Given this list of marker genes Gstp1, Rasgrp1, Vsig4, Aif1, Golph3, Mia3, Hsp90aa1, Cd209e, Il36b, Fadd, Igfbp2, Lef1, Tsc2, Skap1 (src family associated phosphoprotein 1), Cblb, Xcl1, Arg2, Hes1, Arg1, Tnfrsf14, Zbtb7b, Il15, Ptprc, Skint1, Hsph1, Nkap, Smarcc1, Selp, Il4i1, Foxo3, Ywhag, Il6, Smarcd3, Tnfsf14, Ccl21d, Glmn, Slc39a8, Gm5849, Laptm5, Ptpn22, Btla, Il2rg, Arid2, Fgl2, Pdcd1, Erbb2, Vnn1, Mir326, Capn1, Vtcn1, Smarca4, Cyrib, Tnfsf4, Socs1, Cd209d, Zc3h12d, Il21, Ezr, Rc3h1, Klhl22, Lgals3, Zap70, Lilrb4a, Shb, Peli1, Cd81, Pnp, Ptpn2, Phf10, Tnfrsf21, Hspb1, Cd28, Itgb7, Egr3, Foxp3, Msn, Slc4a1, Cd177, Madcam1, Socs5, Sash3, Sart1 (NCBI Gene Id 20227), Mad1l1, Adora2a, Ap3d1, Adam8, Ap3b1, Cxcl12, Cd80, Tespa1, Ascl2, Itgam, Nt5e, Ripk2, Icosl, S100a8, Cd209c, S100a9, Rag1, Tnip1, Cd1d2, Rock1, Cyld, Spn, Dusp3, Vcam1, Chst2, Ambra1, Ccl21f, Il1b, Casp3, Malt1, St3gal4, Il1rl2, Anxa1, Gata3, Epo, Tgfbr2, Itpkb, Stat5b, Pdcd1lg2, Actl6a, Prnp, Kat5, H2-Ab1, Prkcz, Pycard, Jak2, Scgb1a1, Ccl25, Cd6, Ptafr, Runx1, Cd274, Sox13, Il2ra, Il4, Ccl28, Cd244a, Dlg1, Cav1, Smad7, Il12rb1, Ager, Rela, Il20rb, Brd7, Foxj1, Gnrh1, Tnfaip8l2, Ccr2, Fbxo38, Slfn1, Ephb4, H2-Eb2 (NCBI Gene Id 631971), Vsir, Il1a, Ada, Rag2, Actl6b, Flot2, Actb, Cbfb, Nlrp3, Tnfsf13b, Apoa4, Bmp4, Slc7a1, Itga5, Twsg1, Cd27, Ccl21e, Ccl21a, Opa1, Jam2, Bad, Ufl1, Itgb1, Ppara, Has2, Fut4, Ep300, H2-Ea, Sele, Cd47, Marchf7, Smarcb1, Lgals1, Cd24a, Fgl1 (fibrinogen-like protein 1), Nrarp, Irak1, Irgm1, Chst4, Hlx, Cd3e, Sftpd, Pecam1, Icos, Nfkbid, Bmi1, Lgals8, Tarm1, Sell, Akt1, Prkcq, Smarcd2, Igf1, Efnb3, H2-DMb1, Nfat5, Smarcc2, Gimap5, Bcl6, Nr5a2, Sox12, Lck, Wnk1, Zc3h8, Rhoh, Btnl2, Add2, Sema4d, Gimap3, Ctsg, Il23a, Slamf1, H2-DMa, Ccdc88b, Coro1a, Rac2, Rps3, H2-DMb2, Lax1, Brd2, Ndfip1, Tnf, Cd69, Mdk, Ets1, Loxl3, Dock8, Itga4, Lgals9, Il18, Cd55, Zbtb1, Cd59b, Zdhhc21, Pck1, Nck1, Pik3r6 (phosphoinositide-3-kinase regulatory subunit 5), Tbx21, H2-Ob, Ext1, Tfrc, Prkar1a, Dtx1, Pag1, Tnfrsf13c, Tgfb1, Jak3 (Janus kinase 3), Dpp4, Lilrb4b, Klhl25, Pbrm1, Lypd11, B2m, Nckap1l, Sirpa, Dusp22, Igf2, Prdx2, Pten, Klf4, Btn2a2, Blm, Cx3cr1, Card11, Zc3h12a, Nck2, Hmgb1, Cd44, Hfe, Fut7, Cd59a, Ptpn6, Pawr, Fcho1, Podxl2, Pla2g2a (phospholipase A2, group IIA (platelets, synovial fluid)), Gli3, Ephb6, Cd83, Spta1, Lep, Alox5, Zmiz1, Itgal, Dhps, Abl2, Tnfsf9, H2-Eb1, Hspd1, Dusp10, Lrg1, Bmp7, Il12b, Ppp3ca (protein phosphatase 3, catalytic subunit, alpha isoform), Il2, Adk, Slc4a2, Il4ra, Selenok, Ido1, Cd160, Ccl5, Rasal3, Fut9, Tspan32, Sox4, Tyk2, Gpam, Wnt10b, Pla2g2f, Cfh, Cd74, Syk, Cd1d1, Arid1a, Sdc4, Efnb1, Ildr2, Traf6, Irf1, Itch, Olr1, Cd276 (CD276 antigen), Runx3, Smarca2, Scrib, Efnb2, Stk10, Shh, Carmil2, Tnfsf11, Abl1 (NCBI Gene Id 98922), Cd55b, Ccl19, Cd300a, Kitl, Vav1, Cd5, Rara, Tmem131l, Gpnmb, Ctla4, Elane, Cebpb, Pla2g5, Clec4g, Tigit, Zfp35, Ccl21b, Rc3h2, Umod, H2-M3, Ifnb1, Il3, Rhoa, F11r, Gcnt1, Ass1, Il12a, Ifng, Smarcd1, Dlg5, Lag3, Il6st, Pde5a, Lrrc32, Pla2g2d (phospholipase A2, group IID), Zp3, Ripor2, Nr4a3, Ccr7, Crtam, Socs6, L1cam, Cd37, Xbp1, Ihh, Cd46, Il7r, Zfp609, Thbs1, Fermt3, Gp1ba, Havcr2, Smarce1, Ceacam1, Adtrp, Il7, Pf4, H2-Aa, Dnaja3, Selplg, Dapl1, Ccl2, Cd86, Tnfsf18, H2-Oa, Cd4, Zfp608, Cd40lg, Cdkn2a, Lypd10, Nfkbiz, Prkaa1, Itgb2, Brd4, Itgb2l, H2-T23, Thy1, Icam1, Bcl10, Stat5a, here is a description of the gene set: Mouse Gene Set: GOBP_LEUKOCYTE_CELL_CELL_ADHESION species: Mus musculus The attachment of a leukocyte to another cell via adhesion molecules.